Given this list of marker genes Map1b, Mapre1, Arhgef7, Dbnl, Tmod3, Prex1, Mkks (NCBI Gene Id 99133), Mtpn, Coro1a, Dyrk1a, Met, Ccl21d, Ccl26, Mlst8, Kank2, Add3, Psrc1, Sgk1, Arpc5, Fhod3, Fkbp4, Clip3, Camsap2, Tmod2, Nck2, Fer, Stmn1, Pak1, Baiap2l1, Gba2, Arf6, Tmsb15l, Hcls1, Tmsb4x, Rictor, Lats1, Sptbn1, Pfn2, Ccl21a, Rdx, Carmil1, Drg1, Cyrib, Pik3r2, Hspa1b, Snca (synuclein, alpha), Prune1, Ccl24, Stmn2, Cav3, Alox15, Ckap5, Vil1, Ankrd53, Baiap2l2, Nav3, Tmod1, Capg, Bin1, Sptan1, Fes, Add1, Spta1, Twf2, Flii, Cttn (NCBI Gene Id 68623), Cyfip1, Actr3, Cotl1, Vdac2, Hsp90aa1, Arpc3, Myh9, Grb2, Arpc5l, Twf1, Fmn1, Cyria, Tubb4a (tubulin, beta 4A class IVA), Eml2, Rhoa, Tlr2, Daam2, Arfgef1, Kank1, Mecp2, Capza1b, Ssh3, Hspa1a, Tppp, Arhgap40, Washc1, Capn1, Mapt, Camsap3, Ptk2b, Capza3, Sptb, Cfl1, Tppp2, Dmtn, Pfn1, Cdc42ep3, Baiap2, Evl, Gda, Rps3, Cdh5, Cracd, Map2, Slc39a12, Togaram1, Pecam1, Kank3, Bbs4, Git1, Cdc42ep5, Tmsb15b2, Dctn1, Ccl21e, Tenm1, Tpm1, Inpp5j, Snx9, Mtor, Eln, Cav1, Tmod4, Kank4, Slain2, Pfn3 (profilin 3), Fchsd2, Lmod3, Ambra1, Vill, Cdk5rap2, Vasp, Nckap1, Pfn5, Dlg1, Carmil2, Akap9, Add2, Map3k1, Myo1c, Csf3, Fchsd1, Ssh2, Lmod2, Bag4, Dbn1, Nphs1, Arhgap28, Cdc42ep1, Ccl21b, Cyfip2, Nme7, Capzb, Myadm, Kirrel1, Prkcd, Cdc42ep2, Prkce, Numa1, Rasa1, Ccl21f, Slain1, Mapre3, Nckap1l, Mapk8, Tppp3, Abitram, Esam, Avil, Hip1r, Rac1, Hax1, Arl2, Cdkn1b, Ssh1, Ppp1r9a, Gsn, Clip1, Scin, Arpc2, Lmod1, Camsap1, Apc, Svil, Icam1, Cdc42ep4, Ttbk1, Ccl11, Pak3, Gm14137, Pde4dip, Arhgap18, Capza1, Abl1, Capza2, Eps8, Tbcd, Clasp2 (CLIP associating protein 2), Plekhg2, Slit2, Pycard, Nck1, Kif21a, Clec2i, here is a description of the gene set: studied in species Mus musculus Mouse Gene Set: GOBP_REGULATION_OF_PROTEIN_POLYMERIZATION Any process that modulates the frequency, rate or extent of the process of creating protein polymers.